The following is a description of a gene set: A type of ataxia characterized by the inability to carry out movements with the correct range and motion across the plane of more than one joint related to incorrect estimation of the distances required for targeted movements. species: Homo sapiens Dysmetria Human Gene Set: HP_DYSMETRIA, and this is the list of marker genes: NFASC, POLR3B, CLIP2, ABCB7 (ATP binding cassette subfamily B member 7), GJB1, RNASEH1, PDGFRB, UCHL1, PEX16, IFRD1, FTH1, OFD1, PRICKLE1, PMPCB, OPA1, MSTO1, SLC20A2, SCN8A, TBL2, TMEM270, SLC7A6OS, ADPRS, CAMTA1, GJC2 (NCBI Gene Id 57165), TIMMDC1, CWF19L1, VWA3B, TMEM106B, CCDC88C, ATP1A2, LMNB1, PDYN, ATXN7, SQSTM1, RFC1 (NCBI Gene Id 5981), WDR81, TGM6, GPAA1, ABCD1, SLC5A6, ATP1A3, RARS1, PNPLA8, FA2H, SHMT2, ACOX2, PLA2G6, SPTBN2, ANO10 (NCBI Gene Id 55129), NOP56, PRDM13, REPS1, SRPX2, EXOSC5, NDUFAF2, STX1A (NCBI Gene Id 6804), GRID2, PI4KA, BUD23, TWNK, LAGE3, SACS, EIF4H, ITPR1, SLC13A3, CTDP1, BAZ1B, SLC25A46, CACNA1A, MAG, TPP1, PRNP, VPS37D, FXN, CAPN1, WASHC5 (NCBI Gene Id 9897), ABHD12, EBF3, SFXN4, COQ4, DEGS1, DNAJC30, IRF2BPL, ATG5, POLG (DNA polymerase gamma, catalytic subunit, NCBI Gene Id 5428), GTF2IRD1, CHP1, PLP1, SPG7, WARS2, GBA2, MRE11, POU4F1, SLC9A1, KCNC3, XRCC4, CYP7B1, KIF1A, ELN, HIBCH, HTRA1, BRAT1, FMR1, LIG3, GTF2I, ACBD5, ATP6AP2, TTPA, AFG3L2, MARS2, COA7, IVD, UROC1, SCO2 (NCBI Gene Id 9997), SAMD9L, COQ5, SPART, CACNA2D2, ZFHX3, FKBP6, XRCC1, PTRH2, SMC5, NF1, NCF1, AASS, GTF2IRD2, ATN1, YME1L1, ATXN2, ATXN10, COG8, DAB1, LNPK, CRAT, PRKCG, AP5Z1, RFC2, SYNE1, TSPOAP1, GTPBP2, MYORG, TECPR2, TCTN2, TBP, RRM2B, PMPCA, PITRM1 (pitrilysin metallopeptidase 1), METTL27, PDGFB, SLC25A15, CAV1, LRPPRC (leucine rich pentatricopeptide repeat containing), PMM2, VLDLR, RUSC2, TMEM63A, PEX2, TOP3A, B4GALNT1, KIF1C, GRM1, PLD3, MTTP, CLN5, ATXN1, ERMARD, STUB1, OGDH (oxoglutarate dehydrogenase), GFAP, TTC19, ADGRG1, PPP2R2B, POLR3A, PIK3R5, CACNA1G, NGLY1, ELOVL1, LIMK1, NEU1